Given this list of marker genes ABRAXAS2, BRCC3, MPND, BABAM2 (NCBI Gene Id 9577), BABAM1, SHMT2, here is a description of the gene set: species: Homo sapiens Human Gene Set: GOCC_BRISC_COMPLEX A protein complex that contains the FAM175B/ABRO1, BRCC3/BRCC36, BRE/BRCC45 and MERIT40/NBA1 proteins, and specifically cleaves K63-linked polyubiquitin chains.